Given this list of marker genes Ttll6, Cfap45, Cfap20, Bbs4, Catsper1, Bbs1, Bbs2, Gas2l2, Mkks, here is a description of the gene set: Mouse Gene Set: GOBP_REGULATION_OF_CILIUM_BEAT_FREQUENCY_INVOLVED_IN_CILIARY_MOTILITY Any process that modulates the frequency of cilium beating involved in ciliary motility. studied in species Mus musculus